The following is a description of a gene set: Human Gene Set: HP_ABNORMAL_PANCREAS_MORPHOLOGY Abnormal pancreas morphology species: Homo sapiens, and this is the list of marker genes: PDX1, ALG5, GCK, STAT3, B9D2, NEK1, B9D1, CASR, PTF1A (NCBI Gene Id 256297), INS, PRKCZ, FOCAD (NCBI Gene Id 54914), LHX1, CTRC, TXNDC15, MYCN, CEP290, CCND1, RARB, CDKN1C, CEL, KLF11, DYNC2I1, SLC37A4, RECQL4, KCNAB2, PKHD1, GABRD, HNF4A, PDPN, SPEN, SETBP1, RERE, RBM8A, CFTR, KCNJ11, SLC29A3, RPGRIP1L, KCNQ1, SKI, LUZP1, BLK, NPHP3, RFX6, NEUROD1, ENPP1, TMEM67, PRSS2, ALG9, CASZ1, WDR19, CC2D2A, UBE4B, SBDS, PRDM16, MKS1, HNF1A, SIK3, TCTN1, TMEM237, EFL1, GLIS3, TCTN2, ZMYM3, KCNQ1OT1, TMEM231, WNT7B, TMEM107, ABCC6, CNOT1, FOXF1, STRA6, VHL, GATA6, DNAJB11, PRSS1, HNF1B, IFT140, MMP23B, PAX4, FANCD2, ABCC8, SPINK1, DIS3L2, FLNB (NCBI Gene Id 8413), BICC1 (NCBI Gene Id 80114), IGF2, ASXL1, RPGRIP1, TMEM216, PKD1 (polycystin 1, transient receptor potential channel interacting), OFD1, PTRH2, APPL1, XPNPEP3, FLI1, TELO2, CSPP1, DZIP1L (DAZ interacting zinc finger protein 1 like), GANAB, TRPV6, HSPG2, DNAJC21, CPA1, TCTN3, CP, PKD2